Given this list of marker genes CXCL5, AMPD3, RARRES1 (retinoic acid receptor responder 1), BPI, PARM1, KCNJ5, SELENOP (selenoprotein P), ENSG00000255367, TFPI, ZNF398 (NCBI Gene Id 57541), PLPP3, TUT4, VSTM1, RBP1, SCN11A, IGFBP4, LTF, RPS6KA2, CEACAM6, GGA1, LRRC37A2, SLFN13, TMIGD3, CAPN3, SDS, TCN1, SLC18B1 (solute carrier family 18 member B1), ADTRP, CORO2A, TNS1, PRXL2A, ABCB5, PADI4, MGAM, DEFA4, CD24P4, SVIP, ADGRG3, MMP1, FGFR1, ANXA3, ERG, ARMCX1, PGLYRP1, FRMD4A, TMEM37, ATP8A1, CHI3L1, GAPLINC, SPARC, PELI1, MMP24OS, CXCL1, CEBPE, RALGAPA2, MMP9, SLC11A2, HEXA, NUDT7, ALK (NCBI Gene Id 238), LRP3, SFXN5, RGL4, KLHL41, ANOS1, CPNE2, OLIG1, CEACAM8, PTX3, RNU6-82P, BHLHE41, ZNF395, FOLR3, ABCA13, ANKRD13D, OLFML2B, KLF2, CYP4F3, LINC01128, SULT1C2, CD24P2, SLPI, NCF1, ARID2, CEACAM1, TACSTD2, TSPAN2, N4BP2L2, MMP8, IL1R2, S100P, NRP2, HS3ST1, MTUS1, CD24, PPFIA1, PCBP1-AS1, NCOR1, CSTB (NCBI Gene Id 1476), PRDX2, PGA5, SCGB3A1, NEAT1, SYNJ2, KIF21B, FARP1, ARG1, LINC00342, CFLAR, FCGBP, DIP2A, GGTA1, MAF, NUPR1, PYROXD2, KANSL1, CRISP3 (cysteine rich secretory protein 3), SEPSECS-AS1 (SEPSECS antisense RNA 1 (head to head)), CAMK2G, SPAG1, CD59, SLC16A10, ASXL2, LINC00869, DPP4 (dipeptidyl peptidase 4), ELL2, ANKRD18A, PLTP, ITGA9, LGALS12 (NCBI Gene Id 85329), APOE, HP, VRK1, here is a description of the gene set: from publication Takeda A, Goolsby C, Yaseen NR (PMID 16818636) Genes down-regulated in CD34+ hematopoetic cells by expression of NUP98-HOXA9 fusion off a retroviral vector at 16 days after transduction. Human Gene Set: TAKEDA_TARGETS_OF_NUP98_HOXA9_FUSION_16D_DN species: Homo sapiens NUP98-HOXA9, the chimeric protein resulting from the t(7;11)(p15;p15) chromosomal translocation, is a prototype of several NUP98 fusions that occur in myelodysplastic syndromes and acute myeloid leukemia. We examined its effect on differentiation, proliferation, and gene expression in primary human CD34+ hematopoietic cells. Colony-forming cell (CFC) assays in semisolid medium combined with morphologic examination and flow cytometric immunophenotyping revealed that NUP98-HOXA9 increased the numbers of erythroid precursors and impaired both myeloid and erythroid differentiation. In continuous liquid culture, cells transduced with NUP98-HOXA9 exhibited a biphasic growth curve with initial growth inhibition followed by enhanced long-term proliferation, suggesting an increase in the numbers of primitive self-renewing cells. This was confirmed by a dramatic increase in the numbers of long-term culture-initiating cells, the most primitive hematopoietic cells detectable in vitro. To understand the molecular mechanisms underlying the effects of NUP98-HOXA9 on hematopoietic cell proliferation and differentiation, oligonucleotide microarray analysis was done at several time points over 16 days, starting at 6 hours posttransduction. The early growth suppression was preceded by up-regulation of IFNbeta1 and accompanied by marked up-regulation of IFN-induced genes, peaking at 3 days posttransduction. In contrast, oncogenes such as homeobox transcription factors, FLT3, KIT, and WT1 peaked at 8 days or beyond, coinciding with increased proliferation. In addition, several putative tumor suppressors and genes associated with hematopoietic differentiation were repressed at later time points. These findings provide a comprehensive picture of the changes in proliferation, differentiation, and global gene expression that underlie the leukemic transformation of human hematopoietic cells by NUP98-HOXA9.